Given this list of marker genes Ep300, Hdac3, here is a description of the gene set: This event has been computationally inferred from an event that has been demonstrated in another species.<p>The inference is based on the homology mapping from PANTHER. Briefly, reactions for which all involved PhysicalEntities (in input, output and catalyst) have a mapped orthologue/paralogue (for complexes at least 75% of components must have a mapping) are inferred to the other species. electronically inferred by orthology from the curated human pathway studied in species Mus musculus Reactome Pathway: STAT3 nuclear events downstream of ALK signaling part of: Signaling by ALK